Given this list of marker genes PTCH1, CPLANE1, WNT7A, SMO, GLI2, COL18A1, KIAA0586, INPP5E, here is a description of the gene set: Human Gene Set: HP_OCCIPITAL_MENINGOCELE A herniation of meninges through a congenital bone defect in the skull in the occipital region. studied in species Homo sapiens Occipital meningocele